Given this list of marker genes NEUROD4, SEMA3A (NCBI Gene Id 63232), SH3PXD2B, P2RY12, PRKCI, SLC39A5, MERTK, PRSS56, EPHB1, MEIS2, ABCB5, HDAC1, B3GLCT, TGIF2, BMPR1B, CRYGC, CRYAA, BMPR2, RAB18, WNT7B, CRB2, FOXL2, PKNOX1, SDK1 (sidekick cell adhesion molecule 1), BBS1, MEIS3, CLCN2, FKRP, PBX4, HES5, LRP5, NR2E1, DLX1, TBC1D20, LAMC3, ALDH1A2, GJA8, PDE6C, PHOX2B, LHX2, TBX2, RPGRIP1L, IFT172, DLX2 (distal-less homeobox 2), NF1, PSEN1 (NCBI Gene Id 5663), POC5, MFSD8, RAB11FIP4, RD3, BIRC7, B9D1, RING1, FGF10, PITX3, TFAP2B, PAX2, SLC25A25, GNGT1, SERPINF1, SPRY2, NKD1, PER2, ZDHHC16, VEGFA, LHX1, LAMB2, USH1C, SOX12, ABI2, ATP8A2, STAU2, NR2E3, SLC6A3, CASP2, PLAAT3, BSG (basigin (Ok blood group)), MFN2, SMARCD3, SLITRK6, SRF, WT1, IFT140, EPHB2, TMEM135, WNT9A, CALB1, NOTCH2, SAMD11, TULP1, PDGFRA, YY1, GDF11, SLC17A6, PROX1, MED1, HIF1A, SLC17A8, COL4A1, PYGO2, HIPK2, PDE6A, SKI, SPRED1, DTNBP1, SIPA1L3, GPD2 (glycerol-3-phosphate dehydrogenase 2), GNB1, BCL11B, SLC17A7, TTLL5, ARHGAP35, CRYGS, RPL24, WNT6, PHACTR4, RORB (RAR related orphan receptor B), WNT5B, FBN1, SPRED2, CRYBA1, CTNNB1, HSF4, BAK1, CTNS, VAX2, CRYBA4, MYF5, MIP, TGIF1, KDR, MYH15, GRN, FAT1, CEP290, TGFBR2, IHH, PPP1R13L, NF2, BMP7, MAB21L1, ADAMTS18, BCL2, SOX4, SHROOM2, PTF1A, SCO2, RPGRIP1, GDF3 (NCBI Gene Id 9573), HES1, CRYBG3 (NCBI Gene Id 131544), CLDN3, PDGFRB, TMEM132E, SALL2, SIX5, EGFR, WDR19, ATOH7, CRYGA, ULK2, BLOC1S3, ROM1, PXDN, DIO3, COL5A2, MEIS1, ADAMTS9, MAF (MAF bZIP transcription factor), RHO, SOX11, DRD2, SLC38A8, TSKU, CRB1, CDK20, SMARCA4, STRA6, PAX6, GNAT2, AHI1, TENM3, NRL, BFSP2, VSX1, FOXE3, MAN2A1, ISL1, NRP1, GRHL3, CDON, RP1L1, SHH, KERA, DZANK1, THRB, RDH10, FLT1, PFDN5, SOS1, LPCAT1, JUN, LIMK2, AGTPBP1, KLF4, KRT12, PRICKLE1, HMGB1, FOS, OPN5, PRDM1 (PR/SET domain 1), TMEM231, SP3, EPHA2, SKIL, HMGN1, PDE6B, ACHE, MTNR1B, FKBP8, BMP6, ALDH1A3, BARHL2, CRYGN, RARG, MAB21L2, ACVRL1, ATF4, CPAMD8, FOXF2, RS1, CACNA1C, TWIST1, TSPAN12, LENEP, DSCAM, NFIA, TUB, TCIRG1, RAB37, CELF4, FASLG (NCBI Gene Id 356), RBP4, RAB3GAP1 (NCBI Gene Id 338380), ACVR2B, PROM1, TDRD7, ZEB1, BAX, FOXC2, RARB, NHS, KDM2B, FGF2, C12orf57, FAT3, FZD4, ELP6, BBS7, CRYAB, TFAP2A, PRPH2, CHD7, CLIC4, IRX5, SOX2, FRS2, COL8A1, IMPG2, THY1, IFT122, MEIS3P1, VSX2, SMG9, RPE65, EFEMP1 (EGF containing fibulin extracellular matrix protein 1), PTPRM, NPHP4, KDM5B, TWSG1, CRYBA2, NIPBL, MFSD2A (MFSD2 lysolipid transporter A, lysophospholipid), INHBA, COL5A1, FOXP2, SPRY1, POU4F1, FBN2, NAGLU, ZNF513, CRYGD, BBS10, WNT9B, HESX1, VIM, TH, MEGF11, BCAR3, LAMA1 (laminin subunit alpha 1), HPCA, STAT3, PBX1, NDP, AQP5, RPGR, SMOC1, NES, ARL6, RARA, USP45 (ubiquitin specific peptidase 45), CDKN1B, SPRED3, SIX3, MFAP2, OSR2, WNT16, TRAF3IP1, WNT5A, SLC1A1, HDAC2, FZD5 (frizzled class receptor 5), CRYBB3, MTERF4, NTRK3, NECTIN1, NPHP1, PPP2R3A, SAMD7, CC2D2A, MDM1, NOTCH1, ACTL6A, VSTM4, C1QA, PBX2, MYO7A, CHRDL1 (chordin like 1), RP1, TTC8, SDK2, TGFB2, DLL4, RAX, VAX1, ITGAM, GPM6A, FOXC1, MYOM2, MITF, PLAAT1, JAG1, SOX9, PBX3, TMOD1, CNTF, SOX8, SIX6, RHOJ, SCAPER, CRYGB (crystallin gamma B), RDH13, DLG1, LARGE1, CRYBB1, WNT2, ATP2B4, ZHX2, ZEB2, ARHGEF15, FREM2, FJX1, WNT7A, GRHL2, FOXN4, WNT2B, OLFM3, SMAD3, SLC4A5, SLC44A4, NTRK2, CYP1B1, CLN8, DRAM2, TGFBR1, NFIB, POU4F2, XRN2, TMEM215 (NCBI Gene Id 401498), TULP3, HIPK1, DCX, BMP4, WDPCP, MFRP, ANGPTL7, JMJD6, HCN1, TGFB1, COL8A2, LIM2, CYP1A1, DLL1, CLDN19, PITX2, CRYBB2, SOX1, CABP4, ATF6, GRM6, BBS4, GATA3, C3, OPN4, INTS15, GNAT1, AQP1, LCTL, MFAP5, RCN1, FZR1, NECTIN3, PAX4, CACNA1S, NEUROD1, ARSG, CRX, BFSP1, UNC45B, MYH10, GJE1, CITED2, TBC1D32, CDKN1C, GLI3, MYOM1, FGF9, FSCN2, RRM1, here is a description of the gene set: Human Gene Set: GOBP_SENSORY_SYSTEM_DEVELOPMENT studied in species Homo sapiens The process whose specific outcome is the progression of a sensory system over time from its formation to the mature structure.